Given this list of marker genes TCTA, IDO2, NSMCE3, XPO4, MFSD1, JAK1, MTFR1, TMBIM1, CTBP1, GINS1, ACAT1, CMIP, NOP9, SLC25A38, CTSH, ZNF841, VDAC3, MTFR1L, POLR1D, ZDHHC4, N4BP3, NOP16, NCOA6, NAPA (NSF attachment protein alpha), TCEAL9, MRPS26, SC5D, SMC3, FKBP7, RNF5, QRSL1, PTP4A2, SURF6, SSR1 (signal sequence receptor subunit 1), AGFG2, UBP1, APOC3, PAGR1, MRPL28, KYAT3, TRIB3, PABPN1, SYN1, TOP1MT, ZBTB33, RAD9B, CYP51A1, NDUFA13, CCNT2, TMEM208, COA5, TMEM19, OSBP, DPAGT1, PARL, NOXO1, RAP1A, SIRT3, PHKG2, MFHAS1, KPNA1, LAPTM4A, CSF2RA, TRAPPC14, SLC30A1 (solute carrier family 30 member 1), DPH7, SLC25A45, IDH3A, THEM4, SNIP1, CEP85, CCDC115, NUS1, ACLY, SMIM14, CHMP1B, RNASE4, RAB28, DDIT3, DENR, ZFP90, NEDD1, ATP5MG, IRGM, GEMIN2, TRIM25, CETN2, ANXA9, IQGAP3, CDC42SE1, MRPS24, TUG1 (taurine up-regulated 1), TSR1, HNRNPH2, UFSP2, GUSB, KLHL9, PHF23, AGBL5, IRAK4, DIS3, ASCC1, C14orf119, MGAT2, ANGEL2, ANKMY2, SLC6A8, RAB8B, TMEM258, UNK, GOLPH3L, CDH13, MLLT6, KIAA1143, RPE, FKBPL, SELP, RHBDD3, TPP1, RNF144B, ZNF574, NUCKS1, CD2BP2, SRRM1, ASAH1, MYCL, C19orf48P, FRAT2 (NCBI Gene Id 93368), BAK1, LAMTOR1 (late endosomal/lysosomal adaptor, MAPK and MTOR activator 1), TRIM39, MTX1, DUT, GRN, ADCY7, SAP30BP, HCLS1 (NCBI Gene Id 3059), PDK3, ERG28, OST4, CAD, SIKE1, COMMD5 (COMM domain containing 5), SLC1A3, ZIM3, HSPA2, NOG, ZFAND2A, ATP5MC2, FNTA, RETREG1, CD164, HSCB, LYPLA2, NRCAM, MRPL48, WEE1 (NCBI Gene Id 7465), NEAT1, C6orf120, STUB1, ANAPC5, RABGGTA, HOXA11, GADD45G, SREBF1 (sterol regulatory element binding transcription factor 1), CMTR2, GET4, XBP1, MFAP1 (NCBI Gene Id 4236), CORO1A, BLOC1S6, RPP21, RPS9, CPSF2, AKTIP, SRRD (NCBI Gene Id 402055), PDXK (pyridoxal kinase), S100A1, AP3M1, ZNF688, DPH2, BUB1, TNIP2, PPP1R8, SERAC1, VIPAS39, EIF3L, PPM1G, CASP6, LARP1, KCNJ10, STK10, CDIP1, FHIP2A, YME1L1, ABCG8 (NCBI Gene Id 64241), THOC3, BAZ2A, TMEM199, here is a description of the gene set: Genes up-regulated in comparison of control dendritic cells (DC) at 1 h versus those stimulated with Pam3Csk4 (TLR1/2 agonist) at 1 h. studied in species Homo sapiens Human Gene Set: GSE17721_CTRL_VS_PAM3CSK4_1H_BMDC_UP mouse primary BMDCs were stimulated with tlr ligands and gene expression changes were profiled on Affymetrix arrays from publication Amit I, Garber M, Chevrier N, Leite AP, Donner Y, Eisenhaure T, Guttman M, Grenier JK, Li W, Zuk O, Schubert LA, Birditt B, Shay T, Goren A, Zhang X, Smith Z, Deering R, McDonald RC, Cabili M, Bernstein BE, Rinn JL, Meissner A, Root DE, Hacohen N, Regev A (PMID 19729616)